Given this list of marker genes GFRA3, SEC11C, OR51E1, DEPP1, KIF1A, LEFTY1, QDPR, CPE, CLPS, PAPPA2, KLK11, GC, EPCAM, SSR4, CPLX2, FKBP2, RIMS2, APLP1, ANK2, CCKBR, PCLO, BEX3, YWHAQ, WFDC2, GPR160, GPX3, SCG2, PDZRN3, PAM (peptidylglycine alpha-amidating monooxygenase), DPP6, CGA, ARRDC4, PROX1, ALDH1A1, BEX1, SEC62 (NCBI Gene Id 7095), VAMP2, SEZ6L2, IFI6, SLC18A2, AZGP1, LINC00261, MS4A8, SCG3 (NCBI Gene Id 29106), CHGB, PCSK1N, HDC, CMIP, NICOL1, ITGBL1, CAVIN3, DNER, SMOC2, PTF1A, ERO1B, ECE1, ABCC8, PCSK1 (proprotein convertase subtilisin/kexin type 1), DNASE1, SOX4, SCG5, RUNX1T1, GCNT2, CAMK2B, UCP2, CDHR3, ARFGEF3, REV3L, TEAD1, SERPINA1, CHGA, SMOC1, PRSS1, FGF14, ACSL1, PTPRN, ERP27, HEPACAM2, VGF, RAB3B (RAB3B, member RAS oncogene family), CALM1 (NCBI Gene Id 801), KCTD12, SERPINB6, MAOB, RBPJL, here is a description of the gene set: studied in species Homo sapiens from publication Busslinger GA, Weusten BLA, Bogte A, Begthel H, Brosens LAA, Clevers H (PMID 33691112) Human Gene Set: BUSSLINGER_GASTRIC_OXYNTIC_ENTEROCHROMAFFIN_LIKE_CELLS